Given this list of marker genes CIT, WLS, ITPR1, LNPK, TUBB3, CDC40, CCNK, SPATA7, SNX14, AMPD2, RPE65, LRAT, CACNA1G, COG6, APC2, PPIL1 (NCBI Gene Id 5482), CTNNA2 (NCBI Gene Id 1496), ABCC8, TMTC3, LCA5, FOXP2 (NCBI Gene Id 93986), here is a description of the gene set: species: Homo sapiens Delayed early-childhood social milestone development Human Gene Set: HP_DELAYED_EARLY_CHILDHOOD_SOCIAL_MILESTONE_DEVELOPMENT A failure to meet one or more age-related milestones of social behavior.